Given this list of marker genes CDK5R2, ZNF143, NSG1, GAGE12G, CHP1, OGG1, MLANA, NDRG2, GPSM3, PHF20, PHKG1, FAM13A, B3GNT3, FCGBP, ERCC8, CD8A, FUT3, CEACAM4, CYP27B1, OAS2, HPGD, CACNB1, ZP2, TDO2, PPP3CA, SCYL3, GIP, SNAP25, ZBTB7A, HPS1, WASF2, ATOSB, PZP, CRABP1, GRK3, INTS9, GREM1, AKAP7, EXOSC2, H3C6, PIK3IP1, LEFTY1, ABCB9, NMB, MPP3, ARFGAP3, COX6A2, CTAG1B, HTR2A, ASIP, TNFRSF10D, PAX6, TJP1, DCAF7 (NCBI Gene Id 10238), CELSR2, NECTIN1, CSTF2, MYH2, GLE1, HOXB7, LOX (lysyl oxidase), CACYBP, SPINK2, TCL1A, TBX1, ISG20L2, ADAM20, ABCA1, HOXD10, RBMXL2, DCBLD2, CBLN1, RANBP9, ITIH1, TAGLN3, KRT6A, TBXT, KRT33B, PLXNA3, CD86, MPZL2, CBL, GTF2H3, PIK3R3, AGPS, DOK1, SLC7A11, EFNA5, PIM2, CYP2A7, PTPRD, ATP6V1G2, GP9, ZBTB24, DDX18, HOXD4, CEP250, DPYSL4, STAT4, POM121L9P (NCBI Gene Id 29774), IL1RL1, CHP2, DYRK2, FARP2, CDK13, N4BP2L1, MAGEC1, PPT2, SMAGP, SPTB, EDA, NTNG1, POLA1, FMO5, IKZF1, ARID1A, HOXC11, NAT8, MLC1, CSNK2A1, NRG2, PRL, NELFA, POU6F1, LRP6, FKBP6, PTH2R, NR0B2, RRH, AGXT, BNIP1, SOX10, CD72, SYT5, CHST1, REL, ADRA1B, AHSG, ADGRL3, ADA, KRT32, RUNDC3A, EIF1AY, ALOX15, TRIM16, SHBG, DVL1, SKI, RNF216, PLIN1, SLC18A1, ALOX12, KIAA0586, CCNF (cyclin F), MAPK13, PARD3, MSL3, GAD2, CCL16, MYCBP, PIGL, NPR1, GNG4, MEF2C, REPS2, AMMECR1, CELA2B, MAGEA4, RASL10A, RCE1, PGAM2, NEMF, SIX6, MLLT1, CASP2, ITIH4, CSTF3, SLC22A18AS, TRIM10 (NCBI Gene Id 95309), PDCD1, ALPI, CD6, COL19A1, GNG7, HCRT, MPZ, HSF2, MET, TFAP2B, NUDT1, PIAS1, SP140, TRIP13 (NCBI Gene Id 9319), ARID3A, CYP2E1, ELK3, STATH, DUS4L, MAGI1, ALOX12B, SRPK3 (NCBI Gene Id 26576), SLA, SLC17A3, CNTN6, KIF20B, HOXD13, PIK3R2, CAPN3, TBR1, ACTL6B, PRG2, PAX3, ARL4A, GGA2, REG1B, CYP2A6, MYBPC2, SSX4, THRA, MACIR, CYP2D6, PARP2, HTR7, FAM131B, SPN (NCBI Gene Id 6693), TRIM21 (NCBI Gene Id 6737), CD4, NRXN1, MYCL, VAV2, TTC22, HPR, NTRK1, BRME1, BARX2, ZC3H14, SEMA7A, HTR4, SLC4A1, here is a description of the gene set: Human Gene Set: MODULE_7 Genes in the cancer module 7. studied in species Homo sapiens